Given this list of marker genes Xpo7, Zfp92, Mras, Slc1a7, Zfp219 (NCBI Gene Id 69890), Socs3, Cotl1, Hs3st2, Atf7ip, Prkca, Adgrl1, Phf24, Slc38a3, Rap1gap2, Col1a1, Creb5, Atg4b, Hip1, Neu2, Mfng, Timm17b, Mettl26, Larp1, Gnai2 (G protein subunit alpha i2), Wipf2, Tmem222, Misp3, Abcf2, Stk39, Cbfa2t3, Fam163a, Rapgef1, Slc8a1, Ap1m1, Slc16a6, Recql, Hectd3, Tigd5, Clcnka, Gnao1, Mlc1, Ucp2, Gpr107, Mdga1, Stk40, Anks1b, Sh3pxd2a, Kl, Dagla, Fbxo41, Rexo1, Irf2, Cep170b, Sema4g, Son, Pfkfb4, St8sia2 (NCBI Gene Id 20450), A3galt2, Igsf8, Tgs1, Sprtn, Jmjd8, Iqsec2, Cuedc1, Gsk3a, Mpl, Rnf150, Zfp446, Kcnip3, Thap11, Gprc5c, Grin1os, Pdpn, Natd1, Txlna, Cdc42se1, Zfp617, Pik3c3, Thbs4, Fkbp5, Phc3, Slc36a1, Aldoa, Aldoart1, Kremen1, Dlg2, 5031439G07Rik, Trabd, Zbtb4, Hnrnpk, Ncstn (nicastrin), Acot11, Nectin1, Sftpa1, Carns1, Kcnk5, Nnat, Ctdp1, Emilin3, Sdc3, Slc38a1, Adarb2, Grm2, B4galt2, Zer1, Tagln, Crat, Cyp26b1, Usp50 (ubiquitin specific peptidase 50), Mb, Map6d1, Gm6878, Ptpn23, Abcg4, Zfp821, Zfp106, Adgra2, Nfix, Zhx3, Abl1, Srpk1, Kcnk3, Cbx6, Pacs1, Osbpl5, Bod1l, Pnck, Mxi1, Plekhb2 (NCBI Gene Id 98520), Samd4b, Wdfy3, Kcng1, Zfp568, Tanc2, Zfp609, Znrf1, Bptf (bromodomain PHD finger transcription factor), Tnrc6b, here is a description of the gene set: species: Mus musculus Genes predicted to be targets of miRBase v22 microRNA mmu_miR_6940_5p in miRDB v6.0 with MirTarget v4 prediction scores > 80 (high confidence targets). Mouse Gene Set: MIR_6940_5P from publication Chen Y, Wang X (PMID 31504780)